The following is a description of a gene set: A generalized motor seizure is a type of generalized-onset seizure with predominantly motor (involving musculature) signs. The motor event could consist of an increase (positive) or decrease (negative) in muscle contraction to produce a movement. species: Homo sapiens Generalized-onset motor seizure Human Gene Set: HP_GENERALIZED_ONSET_MOTOR_SEIZURE, and this is the list of marker genes: SLC38A3, TSEN34, GRIN2A, DMXL2, TRIT1, PHGDH, VPS53, DNM1L, GRIN1, DDX59, GRM7, SDHB, PIGP, MT-TQ, PRDM8, ADGRV1, TANGO2, BUB1B, AP2M1, PNKP, SATB1 (NCBI Gene Id 6304), TSEN15, MT-ND5, STXBP1, JRK, SLC1A2, GABRD, TBCD, CILK1, MT-ND3, MT-TH, ALDH7A1, CASK, TRAPPC9, PTRH2, GAMT, HACE1, ABCC8, ASAH1, GPHN, PURA, MT-TW, MT-TP, DPM2, FBXL4, COQ8A, CAMTA1, SIK1, LMNB2, DPM1, NTNG1, MAST3, TUBA1A, COG2, PSAP, MT-ATP6, UBE3A, NGLY1, AFG2A, FGF13, STAT3, SYNGAP1, GNB1, BTD, TRIM8, MDH2, MT-TS2, POGZ, BCKDK, ADGRG1, PCDH19, SCN8A, NUS1, MECP2, MT-TK, SDHA (NCBI Gene Id 6389), DYRK1A, KCNA1, GRN, IREB2, GAD1, TBC1D24, MTHFR, SLC32A1, KCNT1, MT-ND6, HCN2, GABRG2, PCDH12, DHFR, PIK3CD, SEPSECS, GABRA1, MT-TF, KARS1, GABBR2, NECAP1, NHLRC1, KCNQ3, STX1B, PIGH, CACNA1A (calcium voltage-gated channel subunit alpha1 A), DPAGT1, MFSD8, SLC6A1, PCYT2, PLAGL1, SLC12A5, SLC4A10, NEXMIF, SLC25A22, ELOVL4, CUX2, SLC25A15, ACSF3, PAFAH1B1, EPM2A, MT-ND4, NDUFA1, NDE1, SCN1A, MT-TV, MT-ND2, KCNQ2, WWOX, SMC1A, KCNMA1, MT-TL1, MED13, ARX, SCN1B, SDHD, MAPK10, NEU1, RPL10, GABRB3, SLC6A19, ARHGEF9, KNSTRN, GALC, NEUROD2, KCNT2, IER3IP1, LNPK, GLB1 (NCBI Gene Id 2720), OPHN1, AFG3L2, CPLX1, PIGT (NCBI Gene Id 94004), APC2, ACBD6, CNTNAP2, ALDH5A1, KCNJ11, PRRT2, MT-RNR1, GABRA5, BRAT1, TMX2, LONP1, COQ5, GCK, SAMD12, GLUL (glutamate-ammonia ligase), DHDDS, SMS (spermine synthase), VPS50, TSEN2 (tRNA splicing endonuclease subunit 2), CLN8, SLC9A6, CARS2, EFHC1, KCTD7, COX8A, EXOC8, DOCK7, CRELD1, TSEN54, NARS1, SLC2A1, EEF1A2 (NCBI Gene Id 6669), DNM1, GNAO1, MT-ND1, PDX1, CTCF, SDHAF1, CHD2, PIGQ, HYMAI, INS, PIGA, CLCN2, SCN2A, MT-TI, PTEN, NSD1, GBA1, PRICKLE1, CDKL5, SCN9A, HCN1, MBOAT7, CACNB4, PACS2